The following is a description of a gene set: studied in species Homo sapiens from publication Farmer P, Bonnefoi H, Becette V, Tubiana-Hulin M, Fumoleau P, Larsimont D, Macgrogan G, Bergh J, Cameron D, Goldstein D, Duss S, Nicoulaz AL, Brisken C, Fiche M, Delorenzi M, Iggo R (PMID 15897907) Human Gene Set: FARMER_BREAST_CANCER_CLUSTER_5 Previous microarray studies on breast cancer identified multiple tumour classes, of which the most prominent, named luminal and basal, differ in expression of the oestrogen receptor alpha gene (ER). We report here the identification of a group of breast tumours with increased androgen signalling and a 'molecular apocrine' gene expression profile. Tumour samples from 49 patients with large operable or locally advanced breast cancers were tested on Affymetrix U133A gene expression microarrays. Principal components analysis and hierarchical clustering split the tumours into three groups: basal, luminal and a group we call molecular apocrine. All of the molecular apocrine tumours have strong apocrine features on histological examination (P=0.0002). The molecular apocrine group is androgen receptor (AR) positive and contains all of the ER-negative tumours outside the basal group. Kolmogorov-Smirnov testing indicates that oestrogen signalling is most active in the luminal group, and androgen signalling is most active in the molecular apocrine group. ERBB2 amplification is commoner in the molecular apocrine than the other groups. Genes that best split the three groups were identified by Wilcoxon test. Correlation of the average expression profile of these genes in our data with the expression profile of individual tumours in four published breast cancer studies suggest that molecular apocrine tumours represent 8-14% of tumours in these studies. Our data show that it is possible with microarray data to divide mammary tumour cells into three groups based on steroid receptor activity: luminal (ER+ AR+), basal (ER- AR-) and molecular apocrine (ER- AR+). Cluster 5: selected 17q21_23 amplicon genes clustered together across breast cancer samples., and this is the list of marker genes: POLG2, CYB561, DHX40, RPS6KB1, VMP1, MTMR4, RNF43, SMG8, SUPT4H1, MED13, SMARCD2, FTSJ3, TRIM37, TACO1, PTRH2, DCAF7, PPM1D, TUBD1, RAD51C (RAD51 paralog C)